The following is a description of a gene set: electronically inferred by orthology from the curated human pathway This event has been computationally inferred from an event that has been demonstrated in another species.<p>The inference is based on the homology mapping from PANTHER. Briefly, reactions for which all involved PhysicalEntities (in input, output and catalyst) have a mapped orthologue/paralogue (for complexes at least 75% of components must have a mapping) are inferred to the other species. Reactome Pathway: The AIM2 inflammasome species: Mus musculus part of: Inflammasomes, and this is the list of marker genes: Aim2